The following is a description of a gene set: part of: Gastrulation Reactome Pathway: Formation of intermediate mesoderm species: Homo sapiens Intermediate mesoderm gives rise to the urogenital system including the gonads and all components of the kidney, with the anterior intermediate mesoderm giving rise to the ureteric epithelium and the posterior intermediate epithelium giving rise to the metanephric mesenchyme. Intermediate mesoderm, is induced by a graded level of BMP signaling between the lateral plate mesoderm (high BMP activity) and the paraxial mesoderm (low BMP activity) (inferred from mouse embryos: James and Schultheiss 2005, reviewed by Davidson et al. 2019). Specification of the intermediate mesoderm in the anterior-posterior dimension is influenced by the caudal-rostral gradient Wnt and FGF signaling and rostral-caudal gradient retinoic acid signaling (inferred from mouse embryos: Cartry et al. 2006, reviewed by Davidson et al. 2019).<br>In mouse, the first observed markers of intermediate mesoderm are Osr1 and Lhx1, which are also expressed in the lateral plate mesoderm. Later, Pax2 and Pax8 are expressed specifically in the intermediate mesoderm. In mouse embryos, knockout experiments indicate that Osr1 activates Lhx1 and Pax2, Lhx1 activates Pax2, and Pax2 activates Lhx1 and Osr1. Foxc1 and Foxc2 produced in the paraxial mesoderm repress Lhx1 and Osr1 and thereby restrict the expansion of intermediate mesoderm.<br>In vitro, human pluripotent stem cells can be induced to form intermediate mesoderm by treatment with a Wnt agonist (CHIR99021) followed by treatment with FGF2 and retinoic acid., and this is the list of marker genes: OSR1, LHX1, PAX2, FOXC1, FOXC2, PAX8, FGF2, BMP4